The following is a description of a gene set: Previous studies have shown that tumor progression in the transgenic adenocarcinoma of mouse prostate (TRAMP) model is characterized by global DNA hypomethylation initiated during early-stage disease and locus-specific DNA hypermethylation occurring predominantly in late-stage disease. Here, we utilized Dnmt1 hypomorphic alleles to examine the role of Dnmt1 in normal prostate development and in prostate cancer in TRAMP. Prostate tissue morphology and differentiation status was normal in Dnmt1 hypomorphic mice, despite global DNA hypomethylation. TRAMP; Dnmt1 hypomorphic mice also displayed global DNA hypomethylation, but were characterized by altered tumor phenotype. Specifically, TRAMP; Dnmt1 hypomorphic mice exhibited slightly increased tumor incidence and significantly increased pathological progression at early ages and, conversely, displayed slightly decreased tumor incidence and significantly decreased pathological progression at advanced ages. Remarkably, hypomorphic Dnmt1 expression abrogated local and distant site macrometastases. Thus, Dnmt1 has tumor suppressor activity in early-stage prostate cancer, and oncogenic activity in late stage prostate cancer and metastasis. Consistent with the biological phenotype, epigenomic studies revealed that TRAMP; Dnmt1 hypomorphic mice show dramatically reduced CpG island and promoter DNA hypermethylation in late-stage primary tumors compared to control mice. Taken together, the data reveal a crucial role for Dnmt1 in prostate cancer and suggest that Dnmt1-targeted interventions may have utility specifically for advanced and/or metastatic prostate cancer. Hypomethylated genes in prostate tissue from mice carrying hypomorphic alleles of DNMT1. Mouse Gene Set: KINNEY_DNMT1_METHYLATION_TARGETS studied in species Mus musculus from publication Kinney SR, Moser MT, Pascual M, Greally JM, Foster BA, Karpf AR (PMID 20584988), and this is the list of marker genes: Slc1a7, Myog, Zdhhc25, Prph2 (NCBI Gene Id 19133), Urad, Abca15, Syna, Sohlh2, Slc12a3, Hal, Trap1a, Ffar3, Sycp2, Aplnr, Pramel1, Nms, Sstr5 (somatostatin receptor 5), Mc4r